Given this list of marker genes Kir3dl1, Tap2, Klrd1, Kir3dl2, Pirb, Tap1, Cyrib, here is a description of the gene set: Binding to a major histocompatibility complex class Ib molecules. Mouse Gene Set: GOMF_MHC_CLASS_IB_PROTEIN_BINDING studied in species Mus musculus